Given this list of marker genes GRIPAP1, LRRC7, HIP1, SLC1A1, VPS35, RAB8A, SCRIB, SACM1L, CLSTN1, VAMP4, CPLX1, GRIP2, NETO1, ARHGAP44, AP3D1, STX3, GRIP1, RAB7A, NSG1, RAB11A, here is a description of the gene set: The directed movement of neurotransmitter receptors. studied in species Homo sapiens Human Gene Set: GOBP_NEUROTRANSMITTER_RECEPTOR_TRANSPORT